The following is a description of a gene set: studied in species Homo sapiens Human Gene Set: GOBP_LIPOPROTEIN_METABOLIC_PROCESS The chemical reactions and pathways involving any conjugated, water-soluble protein in which the covalently attached nonprotein group consists of a lipid or lipids., and this is the list of marker genes: APOA1, NMT2, CTSD, RAB3GAP1, ATM, APOC3, ZDHHC15, LCAT, SVIP, ITGAV, LIPA, IRGM, LDLR, SELENOK, APOLD1, APP, ABHD17C, LYPLA2, DBI, PIK3C3, APOL2, NMT1, PPM1B, SAMD1, CLIP3, PORCN, ABCA1, ZDHHC7, GLUL (NCBI Gene Id 2752), APOD, PPARA, ZDHHC12, APOC2, ZDHHC11, ZDHHC20, APOB, APOE (NCBI Gene Id 99), APOM, ABHD17B, HHAT, ZDHHC6, ZDHHC23, APOA5, NPC1L1, NOTUM, ZDHHC16, ABHD17A, ANGPTL8, HHATL, ALOX12B, APOA4, ZDHHC2, LYPLA1, PPM1A, UGCG, APOL4, APOBEC1, GOLGA7, RABL3 (RAB, member of RAS oncogene family like 3), ZDHHC22, MTTP, ZDHHC3, ATG7, ZDHHC17, ZDHHC1, PPT1, RAB3GAP2, ZDHHC14, APOL3, LEP, MBOAT4, ATG16L1, ZDHHC18, LIPG (NCBI Gene Id 9388), DGAT2, APOL6, ZDHHC21, OLR1, APOC1, ZDHHC9, ABHD10, PCSK9, ZDHHC5, ITGB3, APOA2, APOL1, ZDHHC19, APOL5, ZDHHC8